The following is a description of a gene set: Marker genes curated from the annotated cluster as represented in the Descartes Human Gene Expression During Development database. from publication Cao J, O'Day DR, Pliner HA, Kingsley PD, Deng M, Daza RM, Zager MA, Aldinger KA, Blecher-Gonen R, Zhang F, Spielmann M, Palis J, Doherty D, Steemers FJ, Glass IA, Trapnell C, Shendure J (PMID 33184181) Human Gene Set: DESCARTES_FETAL_STOMACH_PARIETAL_AND_CHIEF_CELLS species: Homo sapiens The gene expression program underlying the specification of human cell types is of fundamental interest. The study authors generated human cell atlases of gene expression and chromatin accessibility in fetal tissues. For gene expression, the study authors applied three-level combinatorial indexing to >110 samples representing 15 organs, ultimately profiling ~4 million single cells. The study authors leveraged the literature and other atlases to identify and annotate hundreds of cell types and subtypes, both within and across tissues. Our analyses focused on organ-specific specializations of broadly distributed cell types (such as blood, endothelial, and epithelial), sites of fetal erythropoiesis (which notably included the adrenal gland), and integration with mouse developmental atlases (such as conserved specification of blood cells). These data represent a rich resource for the exploration of in vivo human gene expression in diverse tissues and cell types., and this is the list of marker genes: GREM2, PRDM16-DT, ALB, CDH10, GLYATL1, ETNPPL, ESRRG, RAB11FIP2, MFSD4A, KCNJ16 (NCBI Gene Id 3773), TRIM50, FGB, CKMT2, ATP4B, SIGLEC11, DHRS2, CLEC3A, ANGPTL3, CYB5R1, ASB11, KCNE2, FGA, PNPLA1, DUSP4, B4GALNT3, APOBEC2, MTCO3P12, CBLIF, PDHA1, GPT2, SERPINA5, AOC3, EPN3, ODAM, MYBPC3, CKM, FAM162A, FRMD1, SULT2A1, AQP4, ATP4A, PAQR5 (progestin and adipoQ receptor family member 5)